Given this list of marker genes LDLR, PARK7, TRIP4, FLOT2, F3, NHERF4, OS9, MARCHF6, KIT, TIMP2, BCL2L10, TTN, PZP, SERPINB3, COMP, VCP, THBS1, ANXA2, CST7, FURIN, PSAP, BCL10, ECM1, SLC2A13, ADAMTSL4, CTSG, NLRP7, PANX1, FAM20C, ELANE, SUMO1, INSL3, CST3, CLTC, SERPINB9, DVL3, LONP2, SH3PXD2A, TNFRSF8, DERL1, SERPINB6, SERPINA1, ACR, SERPINC1, BIN1, BCL2, COL1A2, SRI, SELENOS, CHL1 (NCBI Gene Id 10752), INS, ITGA3, BANK1, MIF, MBP, ADRM1, RIPK2, RIOK3, SEMG2, CNTNAP2, PINK1, NTRK2, TNFAIP3, FCER2, COL3A1, COL1A1, CCBE1, SPATA2, SERPINE1, F2RL3, FN1 (NCBI Gene Id 2335), SERPINB4, SART3, BRCA2, TP53, FAP, LCN2, GSK3B (glycogen synthase kinase 3 beta, NCBI Gene Id 2932), CSTB, POLG, ATP5F1A, MALT1, RFFL, PYCARD, CARD16, MAGEA3, CFLAR, CARD18, VWF, TNF, CARD17P, RNF139, CRADD, NDUFS7, STIM1, SERPINF2, SLC6A3, A2M, ALPI, CD177, TNFRSF10A, FADD, FLOT1, BDKRB2, LCOR, PLG (NCBI Gene Id 90749), NFRKB, SELL, CASP3, ATP9A, CHMP3, PTEN, DPP4, ITGAV, SYVN1, NOL3, TYSND1, BAG6, CDK5R1, ROCK2, RAD23A, ITGB3, PRKN, HDAC3, F2RL1, THAP5, TIMP1, NLRC4, CSTA, XBP1, SERPINB13, BFAR, ITGB1, AMFR, TWNK, IL1R1, PRNP, SERPINA5, ADAMTS4, here is a description of the gene set: Binding to a protease or a peptidase. Human Gene Set: GOMF_PROTEASE_BINDING species: Homo sapiens